The following is a description of a gene set: Stops, prevents or reduces the activity of miRNA-mediated gene silencing activity by base-pairing with a target miRNA. An example of this activity is mediated by long non-coding RNAs (lncRNAs). Human Gene Set: GOMF_MIRNA_INHIBITOR_ACTIVITY_VIA_BASE_PAIRING studied in species Homo sapiens, and this is the list of marker genes: LINC-ROR, MALAT1, DNM3OS, SMAD5-AS1, OIP5-AS1, XIST, HOTTIP, TUSC8 (NCBI Gene Id 400128), NEAT1